The following is a description of a gene set: studied in species Mus musculus part of: Integration of energy metabolism This event has been computationally inferred from an event that has been demonstrated in another species.<p>The inference is based on the homology mapping from PANTHER. Briefly, reactions for which all involved PhysicalEntities (in input, output and catalyst) have a mapped orthologue/paralogue (for complexes at least 75% of components must have a mapping) are inferred to the other species. electronically inferred by orthology from the curated human pathway Reactome Pathway: Insulin effects increased synthesis of Xylulose-5-Phosphate, and this is the list of marker genes: Tkt, Taldo1